Given this list of marker genes PTGES, OR5L2, GALE, CIB4, HIVEP1, LRRC46, MAPKAP1, XRCC5, MSX2 (NCBI Gene Id 8053), HECTD1, ARHGAP11A, CHRNA9 (NCBI Gene Id 55584), DDX19A, DEFB118, TTC21B, RABEP1, APCDD1L-DT, KCTD14, KCNS3, MTCH1, ZNF546, CAPN12, ACAD8, SLC4A5, TMPRSS3, ZNF10, VCL, VSTM1, SMAD7, TAS2R8, GORASP2, LRRC1, KRBA1, KRT222, EID3, TJP2, LINC00856, DNAJB6, CHAC1, LRG1, CSPG5, ALDH1A2-AS1, BCO1, BEND7 (NCBI Gene Id 222389), OCRL, ACSM1, OVOL2, STK39, ENOX2, PCDHB5, ACTR3C, MYT1L, AHR, FASLG, ANGPTL4, DMRTA2, DAOA-AS1 (DAOA antisense RNA 1), MYOG, SMPDL3B, PLAAT2, PLAAT1, PCDHGA1, MLH3, EPAS1, LINC00488, SMIM5, LHFPL5, RWDD4, STXBP5L, FOXRED2, EFHD1, FAM47A, CHAT, PHF24, PRSS16, CLUAP1, EML5, BPIFA4P (BPI fold containing family A member 4, pseudogene), MMP20, DAB1, KRTAP4-7, CACNA1D, HSF5, IQSEC3, MMACHC (NCBI Gene Id 25974), CD6, PLEKHH2, LINC00654, CHD2, TNS4, PPP1R1B, ANKRD31, KRT36, ZNF815P, CLNK, SPACA3 (sperm acrosome associated 3), OR4D1, EHBP1, TRAF3IP1, KLB, EDA, MME, AKR1E2, SSU72L6, SNX10, FBXO39, ZNF736, CBX3P2, DPP10-AS1, SH3RF3, RABGEF1, BMPR2, SEPTIN8, ROPN1B, C1S, NHLRC2, CRLF2, ZC3HAV1, TNFSF11, KLKB1, PIK3CD, MAP3K15, LINC01348, CNN1, LINC00899, SRRM1, MIR9-1HG, HNRNPA3, ZNF185, COL8A1, IL24, MOCS2-DT, CDC45, SNCB, FRMD7, ZBTB2, PRRX2, CEP120, TCF19, TIPARP, STOML1, NT5DC3, KNTC1, BDH1, OSBPL10, LINC00174, C4orf54, LINC01095, PPIC, PATL1, HIPK2, LRRC71 (NCBI Gene Id 149499), CTCF, TNNC2, LINC00330, SLC16A5, N4BP2L1, ZNF93, BPNT2, ROR1, TXNRD3, GAREM2, GCSIR, NNAT, RNF186, CASC2, KAT14, HNRNPA0, USP6NL (NCBI Gene Id 9712), DDX50, OPRK1, CLYBL, SPO11, MRTFB, PTPN3, RNASE1, PID1, MAP2K4, MPO, DGCR5, DOC2B, WHRN, VSNL1, DANCR, TRHDE (NCBI Gene Id 29953), TRA2B, here is a description of the gene set: Removal of the transcription factor SAP1a member of the Ternary Complex Factor (TCF) group of transcription factors which in conjunction with Serum Response Factor (SRF) has been shown to have a profound effect on positive selection in the thymus. When another TCF Elk1 is knocked out in mice there is no effect on positive selection unless it is on a Sap1a KO background where the phenotype is very severe. We have stimulated isolated double positive T cells (DPs) with anti-CD3 to mimic positive selection and compared basal and stimulated transcription across the four genotypes to discover the downstream targets of Sap1a involved in positive selection. species: Homo sapiens Genes down-regulated in double positive thymocytes with ELK1 knockout: untreated versus stimulated by anti-CD3. from publication Costello P, Nicolas R, Willoughby J, Wasylyk B, Nordheim A, Treisman R (PMID 20554967) Human Gene Set: GSE21546_UNSTIM_VS_ANTI_CD3_STIM_ELK1_KO_DP_THYMOCYTES_DN